The following is a description of a gene set: studied in species Mus musculus Mouse Gene Set: GOBP_DTMP_CATABOLIC_PROCESS The chemical reactions and pathways resulting in the breakdown of dTMP, deoxyribosylthymine monophosphate., and this is the list of marker genes: Nt5c, Upb1, Tymp, Upp1, Dpyd, Nt5c3, Dpys